Given this list of marker genes ALOX15B, CNR1, ABHD6, MGLL, GPR55, CAMK2A, CNR2 (NCBI Gene Id 1269), here is a description of the gene set: A G protein-coupled receptor signaling pathway initiated by a cannabinoid binding to its receptor on the cell surface, and ending with the regulation of a downstream cellular process, e.g. transcription. Cannabinoids are a class of diverse chemical compounds that include the endocannabinoids and the phytocannabinoids. studied in species Homo sapiens Human Gene Set: GOBP_CANNABINOID_SIGNALING_PATHWAY